Given this list of marker genes ACAA2, ACADM (acyl-CoA dehydrogenase medium chain), ACADS, ACADSB, HSD17B10, ACAA1, HADHA, HADHB (hydroxyacyl-CoA dehydrogenase trifunctional multienzyme complex subunit beta), ECHS1, HADH, here is a description of the gene set: studied in species Homo sapiens Pathway Definition from KEGG: 2-MB-CoA -- (ACADS,ACADSB,ACADM) >> (ECHS1,HADHA) >> (HSD17B10,HADH) >> (ACAA1/2,HADHB) -> Propanoyl-CoA Human Gene Set: KEGG_MEDICUS_REFERENCE_ISOLEUCINE_DEGRADATION Isoleucine degradation. Pathway ID: N00856. Pathway type: Reference. Pathway class: nt06024 Valine, leucine and isoleucine degradation.